The following is a description of a gene set: species: Mus musculus A structure comprised of a core structure (in most organisms, a pair of centrioles) and peripheral material from which a microtubule-based structure, such as a spindle apparatus, is organized. Centrosomes occur close to the nucleus during interphase in many eukaryotic cells, though in animal cells it changes continually during the cell-division cycle. Mouse Gene Set: GOCC_CENTROSOME, and this is the list of marker genes: Nin, Rassf10, Wrap73, Tpgs1, Mphosph9, Cdkl5, Lrif1, Slain2, Cep192, Slf1, Lhcgr (luteinizing hormone/choriogonadotropin receptor), Ppp4r2, Hnrnpu, Ndc80, Pafah1b1, Cul3, Agtpbp1, Pik3r5, Nme1, Cep152, Cdc42bpg, Il1rn, Haus5, Topbp1, Ninl, Slc1a4, Chodl, Ubxn6, Klhl12, Cep128, Hspa1b, Pcna, Kif23, Ubr4, Ak5, Ttll5, Tnks, Ecpas, Aurkb, Rassf1 (NCBI Gene Id 56289), Azin1, Mapk1, Haus7, Ppp1r12a, Drd4, Ccdc13, Myof, Tesk1, Usp2, Flii, Rab3ip, Poc1a, Polr3h, Hk2, Ttc8, Cep135, Gnai1, Tent5c, Ush1g, Cfap58, Lrrc45, Prkar2b, Fbxl7, Ckap2l, Bbs1, Ift20, Cep20, Map2k1, Ddhd2, Dzank1 (double zinc ribbon and ankyrin repeat domains 1), Dctn2, Cep89, Jtb, Rab11fip5, Entr1, Actr1b, Sclt1, Fam161a (family with sequence similarity 161, member A), Cdk5rap3, Rab34, Psmb5, Tmem201, Dzip1, Mecp2, Disc1, Hipk1, Tmem67, Odf2l, Cep43, Cep72, Odf1, Nek8, Sac3d1, Ccp110, Gnai3, Naa11, Ythdf2, Spag9, Nup62, Spout1, Ccdc28b, Dpf2, Kat2a, Ccdc92, Chd3, Npm1, Calm1, Zfyve19 (NCBI Gene Id 72008), Pdcd6ip, Stil, Ccdc141, Rabl2, Nup93, Nlrc5, Cc2d1a, Ajuba, Fez1, Rapgef6, Ccdc22, Dnajb3, Spdl1, Cep164, Haus4, Cep85, B9d1, Ranbp1, Atm, Ctnnb1, Fam110c, Tapt1, Kif2c, Ccdc57, Procr, Sema4d, Atp6v0d1 (ATPase, H+ transporting, lysosomal V0 subunit D1), Chd4, Nek2, Tap1, Ccdc61, Katna1, Akna, Ypel5, Fbf1, Ndel1, Tubg2, Clasp2, Ctsc, Nme7, Rlbp1, Tchp, Cadps2, Nedd1, Nr3c1, Nsfl1c, Psen1, Pkn2, Hook2, Ndrg1, Dtl, Eya3, Ttc23l, Hdac6, Knstrn, Atp6v1d, Proser3, Tiam1, Cdk6, Fbxo31, Rilpl2, Krt18, Zfp12, Cep95, Obsl1, Skp1, Ppp4r3b, Pskh1, Mastl, Erc1, Map3k11, Eif3a, Ppp4c, Rgs14, Fam184a, Flot1, Rab11a, Sppl2b, Calml3, Cep57l1, Tcp1, Ddx11, Ccdc112, Tgif2, Trim32, Numa1, Map1s, Cct8, Cep112, Septin1, Alpk1, Dync1h1, Pde4d, Psen2 (presenilin 2), Dync1i2, Prkar1a, Tbccd1, Apex1, Ccnb2, Ppp2r3c, Frmd8, Tbcd, Irag2, Arl2bp, Sdccag8, Plk4, Clip1, Khdc3, Atf3, Dclre1b, Cdk5rap2, Taf1d, Neil1, Cenpu, Cspp1, Brsk2, Haspin, Anks1b, Ift81, Ppp2r5a, Cdk1, Ttc12, Spast, Usp33, Grb2, Ttll12, Pkhd1, Dcaf13, Ckap2, Nudcd2, Sass6, Smad7, Actr1a, Dnaaf4, Arhgef7, Tsen2, Wdr13 (WD repeat domain 13), Dbh, Rab23, Fnip2, Rab8a, Sncg, Orc2, G6pdx, Hyls1, Dctn3, Tpgs2, Psma1, Dynll1, Rap1gap2, Trat1, Birc7, Lrrcc1, Mme, Csnk1d, Ak6, Ift27, Tcea2, Cep55, Mllt11, Bbs5, Mcph1, Dynll2, Nphp4, Bicd1, Klhl4 (kelch-like 4), Mks1, Ccdc124, Mcm3, Fbxl13, Dctn1, Calm2, Aldob (aldolase B, fructose-bisphosphate), Lats1, Vps37a, Alms1, Clasp1, Map7d1, Ccno, Cep44, Snx10, Dnm2, Katnip, Ift80, Nckap5l, Pak1, Ccnf (cyclin F), Poc1b, Rabgap1, Rac1, Brca1, Mfap1a, Washc1, Gpr174, Cep162, Dctn5, Rnf19a, Ift52, Ska3 (NCBI Gene Id 219114), Rad18, Podxl, Kif13a, Atf5, Hook3, Rtraf, Snap29, Crocc, Tubgcp5, Lrrc49, Cep250, Ssx2ip, Lats2, Slc8a3, Spag5, Cdc45, Tbc1d31, Mzt2, Rassf7, Kif2b, Git1, Naa12, D1Pas1, Bnip2, Vps4b, Kat2b, Pja2, Dyrk3, Cfap144, Dcaf1, Ahi1, Rps7, Ubn1, Clic4, Stox1, Apc, Bicdl1, Cep85l, Mdh1, C2cd5, Gen1 (GEN1, Holliday junction 5' flap endonuclease), Bicd2, Pfdn1, Mapkapk2, 4933427D14Rik, Slc18a2, Aaas, Cenpj, Ccdc8, Etl4, Patj, Jade1, Usp50, Fsd1 (fibronectin type 3 and SPRY domain-containing protein), Dnai1, Dync1li2 (dynein, cytoplasmic 1 light intermediate chain 2), Cep170, Haus2, Kif3b, Ift46, Ska2, Id1, Ttc39a, Enkd1, Klhl22, Ift57, Haus8, Nit2, Nfs1, Cdkl2, Ppp1r42, Rpgr, Cetn4, Cep57 (centrosomal protein 57), Actr8, Brsk1, Kifc1, Bccip, Pde4dip, Limk2, Ccne1, Ift88, Dynlrb2, Dyrk1a, Pax2, Brca2, Misp, Cfap298, Nek6, Traf3ip1, Mtus2, Mplkip, Exoc4, Cct4, Mamld1, Cep104, Tube1, Cntrob, Ccdc15, Pcgf5, Dennd1c, Nubp2, Cep131, Cep120, Lck, Prkcq, Nde1, Cabcoco1, Nfe2l2, Trip4, Ankrd7, Gli2, Fam110b, Cluap1, Kif18a, Rapsn, Rragd, Cetn3, Spatc1l, Rbbp6, Nek7, Traf5, Ccdc18, Kif24, Hspa1a, Cenpf, Ric8b, Pxk, Haus3, Rabep2, Haus6, Gpsm2, Mpp1, Pacsin2, Ift140, Aurkc, Itsn2, Aunip, Ruvbl1, Dync2i2, Ndn, Rabl6, Cep295nl, Ccdc146, Clic5, Tacc1, Rad51, Yes1, Pcm1, Caprin2, Hsf1, Cd2ap, Wdr35, Nudt21, Iqcb1 (NCBI Gene Id 328669), H2ax, Rad51d, Plk3, C2cd3, Bod1, Rita1, Exoc7, Arl3, Gle1, Xrcc2, Zfp322a, Cenatac, Tubgcp4, Crmp1 (NCBI Gene Id 12933), Rgcc, Aurka, Ccnb1-ps, Axin2, Diaph1, Tubgcp2, Mzt1, Lzts2, Marchf7, Emd, Nlrc3, Mak, Serinc5, Triobp, Slmap, Ift22, Dlgap5, Als2, Prkar2a, Lrwd1, Cdkn1b, Harbi1, Dync1li1, Rttn, Ttc28, Sgo1, Cyld, Mkks, Arl2, Asap1, Pibf1, Relb, Upf3b, Tmem63a, Spice1, Ccdc85b, Mfap1b, Mapre1, Fbxw11, Poc5, Ankrd26, Tek, Creb1, Abraxas2, Filip1l, Ckap5, Dis3l, Zfp365, Ptpn23, Rock2, Kmt5b, Cul7, Tacc2, Ccdc14, Mid1, Ptpn20, Kif2a, Rrp7a, Dhx9, Cfap53, D7Ertd443e, Bbs2, Ppp4r3a, Prkaca, Kifap3, Rrm1, Dync2li1, Acads, Gpaa1, Hepacam2, Kiz, Wdr90, Chek1, Hook1, Itgb6, Plk2, Uvrag, Katnb1, Arhgef10, Plekha7, Gsk3b, Prpf6, Espl1, Ccdc116, Ccsap, Mvb12a, Rab11fip3, Sirt2, G6pd2, Ccnb1, E2f1, Zmynd10, Braf, Atf4, Cetn2, Pqbp1, Ccdc88b, Cdh23, Nr0b1, Cep126, Ddx3x, Eps8l2, Ift74, Plk5, Fam110a, Map7d2, Tmub1, Hormad2, Phf1, Ccdc96, Cetn1, Cntrl, Camsap3, Cep41 (centrosomal protein 41), Cby1, Mdm1, Keg1, Steep1, Birc6, Tex9, Ccdc38, Naa40, Akap9, Mark4, Flcn, Rpp25, Cep97, Calm3, Plk1, Mplkipl1, Nek9, Ofd1, Cep68, Odf2, Unc119, Cdc27, Dynlrb1, Stk11, Mib1, Dctn4, Ilk, Ptk2, Fance, Stap1, Kmt2e, Fign, Dysf, Hmbox1 (homeobox containing 1), Ccdc88a, Kif20b, Dcdc2a, Cd86, Ift56, Ccdc187, Zfyve26, Luzp1, Ccdc66, Bcl2l1, Cep63, Ccdc88c, Gnai2, Kif3a, Ctdp1, Tnks2, Nek1, Cyth4, Efhc1, Keap1, Rilpl1, Stx1b, Prkacb, Camsap2, Csnk1a1, Wrn, Dtx4, Cep83, Itgb1bp1, Ubxn2b, Pcnt, Dctn6, Zbed6, Cdk2, Spmip4, Cntln, Plag1, Ruvbl2, Pard6a, Prkcb, Cct5, Kif5b, Bcas2, Katnal1, Cep295, Plekhg6, Cep290, Sfr1, Tubgcp3, Ocrl, Cep76, Il4ra, Ccdc77, Cep70, Tacc3, Nubp1, Ska1, Hap1, Trp53, Dynlt2b, Ercc6l2, Uxt, Camk2b, Arfgef2, Ctnnbl1, Vps4a, Cdc25b, Usp20, Ranbp9, Cdc16, Cep350, Ccdc113, Mad1l1 (MAD1 mitotic arrest deficient 1-like 1), Cep19, Tubg1, Kifc3, Dync2i1, Magi2, Ist1 (NCBI Gene Id 71955), B9d2, Ppp1r35, Ift70a1, Marcks, Ift25, Haus1, Spatc1, Cdc42, Wdr62, Ilrun, Bbs7, Crocc2, Usp9x, Trim69, Bloc1s2, Bbs4, Cdc20, Ssna1, Leo1, Macroh2a1, Capn7, Smad4, Pclaf, Tubgcp6, Hnmt, Aspm, Dapk3, Mdm2, Scyl1, Tsg101, Ivl, Ski, Trappc14, Rbm39, Txndc9, Eef1akmt3 (NCBI Gene Id 546486), Map10, Ola1, Cstpp1, 2700049A03Rik (NCBI Gene Id 76967), Bud31, Pde4b, Fry, Cir1, Ift43, Cpeb1, Ccdc42, Cfap96, Stk3, Ccdc81, Dcaf12, Bbs9, Cep78, Hmmr, Hoxb4, Slc16a1, Parp3 (NCBI Gene Id 320721), Evi5 (NCBI Gene Id 231572), Cdc14a, Pdzd2, Cib1, Sorbs1, Rpgrip1l